Given this list of marker genes AGO4, LMLN, CPEB4 (cytoplasmic polyadenylation element binding protein 4), POU2F1, MON2, MTMR12, SREK1IP1, NAA40, ADAMTS3, ZNF678, IGF1R, RB1, ARMT1, STRBP, IGF2BP1, SULF2, IPO5, CYTH3, RNF13, BCL7A, COL9A3 (collagen type IX alpha 3 chain), IL36G, FKRP, BSN, SLC16A10, RGS16, SGO1, B4GALT4, GHR, ONECUT2, MCTS1, FBXO22, LIN28B, TSPAN2, ZNF799, PGRMC1, ARHGEF38, LOXL4, COL6A3, SULT1C2, MMD, XRN1, CEP164, SHANK2, GALNT1, GXYLT1, CCDC68, IL10, ADCY9, PPARGC1B, CACNA1E, CPED1, PTPRD, LAMA1, ABHD13, VCAM1, FAM135A, ADAMTS8, CCND1, USP44, GABPA, SLC16A9, IGDCC3, IKZF2, ANKRA2, TECPR2, EYA3, CCND2, ARK2C, SPIRE1, SLC31A2, UBE3D, ROCK2 (Rho associated coiled-coil containing protein kinase 2), SCEL, CPEB3, CEP85L, ROCK1, DNAJC1, LBH, MS4A7, CDC34, YPEL2, PTPRO, RBFOX1, ICE2, MYCN, GALNT4, NIPA1, ACVR2A, GNPTAB, CELF5, ENOX2 (NCBI Gene Id 95974), FAM180A, ALKBH1, TEX261, GRAMD2B, ZSWIM5, HNRNPC, MOB4, SNX5, POSTN (periostin), COL4A2, RAG1, SLC38A9, RAB11FIP2, LIMD1, FIGN, CCDC186, SLC30A4, FBXO30, CNOT6, MEAK7, GALNT2 (NCBI Gene Id 2590), SLC7A14, TSPEAR, LPGAT1, PEG10, IPO11, ZNF823, ADIPOR2, KDM3A (lysine demethylase 3A), PRTG, DICER1, MEF2C, SMIM3, KPNA1 (NCBI Gene Id 3836), RD3L, DMD, POGZ, GTPBP2, MMP1, PPARA, TBKBP1, SH3RF3, DENND11, GPCPD1, CCNJ, TMC7, SYT2, CPEB2, PARD6B, EVI2B, TET2, IGF2BP3 (NCBI Gene Id 10643), MEX3A, FIGNL2, DZIP1 (DAZ interacting zinc finger protein 1), NAP1L1, LRRC59, HECTD2, TRIB1, GALNT12, PURG, UTRN, ASAP1, MAPK9, RNF139, HAS2, LRIG3, NDST3 (N-deacetylase and N-sulfotransferase 3), CNOT6L, MSI2 (NCBI Gene Id 124540), RCN1, COL15A1, CD276, TET3, CTDSPL2, BEND4, KCNC2, MTCL3, SENP5, BORA, MAP4K3, GMPR2, GNG2, EPHA3, COL4A1, MEST, C14orf28, RBFOX2, DUSP1, ENTREP2, SIMC1, FRMD4B, RIMS3, MYRIP, CLOCK, DTX4, RORC, HSPE1-MOB4, NPHP3, ARID3B, ARHGAP12, ACTA1, TAB2, ZNF443, HMGA2, VANGL2, RFESD, STARD3NL, ANKRD52, SENP2, THOC2, ADRB2, AGAP1, FOXN3, POC1B-GALNT4, PAPPA, SLC9A9, PLEKHO1, ATXN7L2, ZNF516, SKIL, SPCS3, XKR4, CAP1, TMEM65, RAB8B, PTAR1, TNRC6B, NID2 (nidogen 2), TRHDE, STARD13, IPO7, NECTIN3, BTG2 (NCBI Gene Id 7832), ATL2, CLCN5, TRIM71, NIPAL4, DLC1, IL6R, CD164, PXDN, AGBL2, STON2, NRK, GTF2I, PIK3IP1, CERT1, CAPN6, COL27A1, SCYL3, SMAP1, C8orf58, LEPROTL1, ARL5A, here is a description of the gene set: studied in species Homo sapiens Genes predicted to be targets of miRBase v22 microRNA hsa-miR-202-3p in miRDB v6.0 with MirTarget v4 prediction scores > 80 (high confidence targets). Human Gene Set: MIR202_3P from publication Chen Y, Wang X (PMID 31504780)